The following is a description of a gene set: Human Gene Set: GOBP_AMP_SALVAGE studied in species Homo sapiens The chemical reactions and pathways resulting in the formation of adenosine monophosphate (AMP) from derivatives of it (either adenine, ADP or adenosine 3',5'-bisphosphate) without de novo synthesis., and this is the list of marker genes: ADSS1, APRT, HPRT1, ADK, ADSL, ADA